The following is a description of a gene set: Genes having at least one occurrence of the motif TRGRRGGAAGTKKSST in the regions spanning 4 kb centered on their transcription starting sites. This matches the MAF transcription factor binding site V$MAF_Q6 (v7.4 TRANSFAC). Human Gene Set: MAF_Q6 studied in species Homo sapiens, and this is the list of marker genes: SMARCA1, RRAS, NKX2-1, FXYD4, AIF1, FOXP2, GAS7, CXXC5 (NCBI Gene Id 51523), KATNB1, TIMELESS, NUMB, INSRR, MEOX2, ALCAM (NCBI Gene Id 214), CLNS1A, HMGA1 (high mobility group AT-hook 1), SAMM50, CDK8, CHIC2, CBLN2, PCDH10, MIDEAS, FGD2, HMGB3, KMT2A, RARB, EFNB3, PEPD, VAMP3, BMP4, NLK, TUSC3, KIF16B, TMEM256, SUPT16H, LAMP2, SYNCRIP (synaptotagmin binding cytoplasmic RNA interacting protein), PRDX6, SLC44A1, NUP214 (NCBI Gene Id 9680), NCOA3, TMEM97, HOXB8, CBX8, BMF, CSRNP3, ERC1, GABRA3, VCAM1, CD79B, SPAG9 (NCBI Gene Id 9043), KDELR2, MEIS2, TIAM1, FGF13, GPR82, CALN1, SAT1, FLT1, SEMA4A, UTP18, NRG2, AAMDC, TNKS, TRAPPC8, NUFIP2, AKAP13, CD5, PTGER2, ZBTB18, OGG1, ETV3, UNC5C, ERLIN2, STAC2, RSF1, PDGFRA, HYCC1, NEGR1, NOVA2, ACTR2, BRDT, BNC2, WDR81, CCR10, DYRK1A, RASSF3, TYSND1, GOLGA2P7, TGFBR1, TRERF1, SOX2, ESRRG, RBFOX1, MITF, S1PR2, SIX1, ELOVL6, PGRMC2, ITPKB, ALDOA, HOXC6 (homeobox C6), RBM26, R3HDM1, COP1 (NCBI Gene Id 64326), KDM6A, CPNE1, PTBP3, SLC34A3, CHM, PDZD7, PCDHAC2, ATOSB, SIX4, HHATL, AP2M1, AMOT, TWIST1, CACNB3, WNT3, TTC3, WDR54, KRCC1, TBC1D8B, HAS2, WIPI2, MAP1S, CDC5L, SLC41A1, HMGCS1, PROK2, DDX17, PTPN7, LPAR1, TAOK1, SP3, EPS15, E2F4, PIK3CD, SATB1, RARA, MRPL49 (mitochondrial ribosomal protein L49), DENND2D, MAP4K5, CNOT7, SNCG, TFEB, ITPR1, ZNF512, PIK3CG, SLC35B3, SLC4A2 (solute carrier family 4 member 2), CREB3L2, TNFSF10, DDX50, GGNBP2, VPS37A (NCBI Gene Id 23687), SQLE, BAD (BCL2 associated agonist of cell death), NHERF1, EXOC3L1, LMAN2, HOXC4 (NCBI Gene Id 50712), ESM1 (endothelial cell specific molecule 1), CNTNAP1, SP8, GPX1, GRHL3, HOXB4, KCTD15, RPS6KA3, SNAP25, HNF1B, SLC16A6 (NCBI Gene Id 9120), VAV2, RAB33A, FLOT2, LCOR, GRM3, TPRG1, POLG, PI4KB, BMP5, FAM13B, SKIDA1, PPP2R5C, FBXL18, CYTOR, ADORA3, KCNJ16, RORA, CNTN4, BLTP3A, MAP4K2, SYTL1, KPNB1, MGLL, JMJD1C, SH3RF1, TLK2, CORO1C, GPC4, GAB2, CDH13, PHF12, ALX3, OTP, MIR22HG, PRKAG1, SLA, ST20-AS1, PAX6, NPAS3, RASGRP3, RNF44, CTDSPL2, NXPH4, S100G, TMEM255A (transmembrane protein 255A), STAT6, MBD6, MSL3, FEZF2, IKZF2, LIN28A, HMGN2, TLX1, ACTN1, AFF2, NFAT5, LZTS2, PHC1, MMRN2, NOL4L, CHD2, MPO, DMP1, HYAL2, STK4 (serine/threonine kinase 4), ZNF570, WDR82, CDK5, AGPAT4, STX12, PNRC1, CUL2, HEPACAM, ADAM2, AKT3, NKX2-2 (NK2 homeobox 2), LALBA, ZNF710, PGF, POU2AF1, FAM78A, ZHX2, ELAVL4, TPBG, COL1A1, OTX1, PTPN22, PPM1E, CHAD, SYNPR